Given this list of marker genes Cbx7, Wnt10a, Rbpj, Zdhhc21, Tfap2c, Gsdma3, Ext1, Krt76, Scd1, Smad4, Acer1, Gata6, Fa2h, Ash1l, here is a description of the gene set: studied in species Mus musculus The process whose specific outcome is the progression of the sebaceous gland over time, from its formation to the mature structure. Mouse Gene Set: GOBP_SEBACEOUS_GLAND_DEVELOPMENT